Given this list of marker genes DUSP1, PARP8, DIDO1, FAM66D, SLTM, DHX40, PTGES, APBA1, CX3CR1, GZMA, HTRA2, CENPU, HGF, GIMAP6, PCDH1, MAP1LC3B, P2RY10, PPP2R5A, STAT5B (NCBI Gene Id 6777), SKP2, WASF2, SLCO3A1, BRD7 (bromodomain containing 7), TNFRSF11B, NOCT, TTLL5, CTCF, RPF1, VAMP4, FOXJ2, SUPT20H, USP15, ADGRE1, RPL34, MACF1, TCAP, ARHGEF15, ZNF205, GIT2, TTF1, CCDC69, USF2, PTPRC, MIA, HBP1, ETS2, RAB4A, SAP30L, PAPOLA, RPL7, RNF10, PSMA2, MS4A5, GABRB1, HBZ, SMC4, TRANK1, EXOC1, ALOX5, GNPAT, ARHGAP15, ULBP2, SYNE1, YPEL5, SMPD3, TNFSF11, PIGA, ZCWPW1, MTMR1, RSRP1, CTSK, TMEM140, CCR5, DNTT, RB1CC1, ZFY, PELI1, PDE4D, KATNIP, TMEM156, FBLN5, ARAP2, UBE2J1, DNAJC3, POLR2A, SFXN1, FLT3LG, TCL1A, CAPRIN2, RPL31, PMS2P2, SLC4A1AP, RTF1, VCPIP1 (valosin containing protein interacting protein 1), GRIK2, HTR4, DUSP11, ANKRD55, XRCC1, C3AR1, TMSB10, PJA2 (NCBI Gene Id 9867), PMAIP1 (phorbol-12-myristate-13-acetate-induced protein 1), PDE6G, AKAP17A, CCDC59, ZNF395 (NCBI Gene Id 55893), BCAR3, ACOX1, SATB1, BACH2, ABHD5, CSF2, UBB, BEGAIN, FAU, CD48, SIAH2, MTERF1, MYD88, PTPN2, DENND3, RASSF2, ISG20, NF1, EVL, CTBP1, CDC14A, RAMP1, UBE2D2, ARL4C, HBQ1, SPTBN1, KBTBD2, CEP63, CA8, IFITM2, TRIM25, MTARC1, GDPD3, ADD3, CCDC198, TRIM37, GAREM1, LMBRD1, PILRA, GSE1, TMEM50A, SINHCAF, ACTB (NCBI Gene Id 60), CCND3, HSDL2, RAB31, LILRB2, NECAP1, UTRN, GNL1, HLA-A, ATP10D, SCCPDH, SELPLG, ALOX5AP, ZNF292 (NCBI Gene Id 23036), JAK1, ZNF211, REM1 (RRAD and GEM like GTPase 1), RAD51B (NCBI Gene Id 5890), TMEM59, TMEM164, GUSBP11, DYM, N4BP2L1, CTDSP2, NIPAL3, ZNF106, H2BC12L, RNF38, COQ8A, EPAS1, CPEB1, ZFYVE16, FBXL8, HEXIM1, OSGIN2, PHAF1, SEMA3C, CD300A, L2HGDH, VCL, KMT5B, TMEM230, PCNX1, KDM5A, ARHGDIB (NCBI Gene Id 397), CYLD, TRBC1, LGALS8, DAZAP2, NRDC, here is a description of the gene set: studied in species Homo sapiens In the present study we used Affymetrix oligonucleotide microarrays to produce gene transcription profiles for the major leukocyte types in humans. This comprehensive dataset enabled us to not only establish which genes were expressed in each leukocyte type, but also which genes were expressed in each subset after activation. The used of a comprehensive dataset of gene profiles from all the major human leukocyte subsets enabled a novel and powerful means for identification of genes associated with single leukocyte subsets, or different immune paradigms. from publication Jeffrey KL, Brummer T, Rolph MS, Liu SM, Callejas NA, Grumont RJ, Gillieron C, Mackay F, Grey S, Camps M, Rommel C, Gerondakis SD, Mackay CR (PMID 16474395) Genes down-regulated in comparison of mast cells versus basophils. Human Gene Set: GSE3982_MAST_CELL_VS_BASOPHIL_DN